Given this list of marker genes ELOVL4 (NCBI Gene Id 94678), UNC119, PRPH2, TIMP3, CFH, ALDH3A2, PROM1, IMPG2, CNGB3, CFHR3, IMPG1, ABCA4, EFEMP1, HGSNAT, BEST1, HMCN1, CFHR1, CFI, APOE, here is a description of the gene set: species: Homo sapiens Human Gene Set: HP_YELLOW_WHITE_LESIONS_OF_THE_MACULA Yellow/white lesions of the macula